Given this list of marker genes Exosc9, Exosc10, Exosc2, Exosc8, Exosc3, Trnt1, Zcchc7, Exosc7, here is a description of the gene set: The set of processes involved in identifying and degrading defective or aberrant tRNAs. Mouse Gene Set: GOBP_TRNA_SURVEILLANCE species: Mus musculus